Given this list of marker genes UGCG, ENTPD5, SCRIB, BLCAP (BLCAP apoptosis inducing factor), PPIG, ZFYVE1 (NCBI Gene Id 57694), EZH1, ADCY7, PCMTD1, TMEM106A, CYP2S1, PRCC, BLTP1, RBM43, MYH9, EXOC7, MMP9, PRKX, PLBD2, UNC45A, EI24, RABGAP1, SCAF8, MARCHF7, B4GALT7, TRPV2, TBC1D20, ZNF646, ATF7IP, SNAPC2, CAPNS1, FBXL20, ABRAXAS2, GPR108, GLG1, FBRS, ATE1, FBXW4, SLC35C1, DDX60, NMI, ILRUN, PFN1, GABARAP, WASHC1, MAP3K11, BRPF1, RPTOR, PRR14L, PACS1, SP1, HPCAL1, NCLN, FXR2, PPP1R21, NAPRT, CARF, WDR82, EID1, ARL8A, ZMYM2, PDCD7, TRAF2, CC2D1B (NCBI Gene Id 84499), PPME1, FBXW8, LNX2, NISCH, ZC3H7A, SRRM2, HDAC7, MPHOSPH9, RDH5, RAB27A, ATXN7L3, OPA3, NFATC2IP, CCDC97, SPRED2, URM1, RC3H2, HOMER1, TADA3, ABI1, ESS2, UBR1, ZNF384, CDC14B, ARHGEF7, DCAF4, STK11IP, FAM219A, FHIP2B, UNC5CL, TRIM41, ZC3H3, KDM2B, PIP5K1C, MAN1C1, MAPKBP1, ST3GAL2, MFSD14A, ADH1C, MAP3K14, CCNL1, LINC00511, DTX1, TCHP, SACS, PPOX, CCDC88B, FCRL1 (Fc receptor like 1), MX2, AKR1B1, DEPDC5, NEURL4, UGGT2, ST6GALNAC3, DMAC2, RPS6KA2, ZUP1, AGPAT1, RAB3GAP1, MEF2D, PARD6G, WDR83OS, SECISBP2L, PDCD4, HSF1, THUMPD2, ZBED6, GLS2, ARAP1, TTLL3, PBRM1, CAMK2B, PHF20L1, GIMAP6, MAEA, ITGA10, NEK8, FCSK, NBEAL1 (neurobeachin like 1), FAS, YEATS4, LIMD2, PDXDC1 (NCBI Gene Id 23042), EGLN2, STRADA, TENT4A, PTBP1, GALNT6, GRINA, CABLES1, TPR, PCNX1, ARID4A, FBXW5, RALGPS2, HGS, RPS10, HP1BP3, TMEM87B, RPH3AL, IFT122, RASGRP2, BAZ2B, CEP95, PLGRKT, HERPUD2, EPC1, ISY1, ZBTB42, MDM4, NNT, ZBTB40, CNOT3, AP1G2, COG4, PRPF6, NELFA, NBR1, NPEPL1, STING1, ZC3H18, UPF2, SLC16A5, SYNJ2, KLHL20, UNKL, BCL9L, BAX, TMEM101, SLC4A10, ZNF687, KIF13A, PEAR1, SMPD5, CRTC1, HLA-B (NCBI Gene Id 730410), here is a description of the gene set: After activation, CD4+ helper T (Th) cells differentiate into distinct effector subsets. Although chemokine (C-X-C motif) receptor 5-expressing T follicular helper (Tfh) cells are important in humoral immunity, their developmental regulation is unclear. Here we show that Tfh cells had a distinct gene expression profile and developed in vivo independently of the Th1 or Th2 cell lineages. Tfh cell generation was regulated by ICOS ligand (ICOSL) expressed on B cells and was dependent on interleukin-21 (IL-21), IL-6, and signal transducer and activator of transcription 3. However, unlike Th17 cells, differentiation of Tfh cells did not require transforming growth factor b (TGF-b) or Th17-specific orphan nuclear receptors RORa and RORg in vivo. Finally, naive T cells activated in vitro in the presence of IL-21 but not TGF-b signaling preferentially acquired Tfh gene expression and promoted germinal-center reactions in vivo. This study thus demonstrates that Tfh is a distinct Th cell lineage. from publication Nurieva RI, Chung Y, Hwang D, Yang XO, Kang HS, Ma L, Wang YH, Watowich SS, Jetten AM, Tian Q, Dong C (PMID 18599325) species: Homo sapiens Human Gene Set: GSE11924_TFH_VS_TH2_CD4_TCELL_UP Genes up-regulated in comparison of T follicular helper (Tfh) cells versus Th2 cells.